The following is a description of a gene set: studied in species Homo sapiens Human Gene Set: GOBP_MIDDLE_EAR_MORPHOGENESIS The process in which the anatomical structures of the middle ear are generated and organized. The middle ear is the air-filled cavity within the skull of vertebrates that lies between the outer ear and the inner ear. It is linked to the pharynx (and therefore to outside air) via the Eustachian tube and in mammals contains the three ear ossicles, which transmit auditory vibrations from the outer ear (via the tympanum) to the inner ear (via the oval window)., and this is the list of marker genes: TBX1, NAGLU, EDNRA, HOXA2, MSX1, PRKRA, SIX2, FGFR1, OSR1, SIX1, MYC, INSIG1 (insulin induced gene 1), TSHZ1, GSC, EYA1, NKX3-2, INSIG2, OSR2, PRRX1, RPL38, NOG, EDN1